Given this list of marker genes Cetn1, Tuba1a, Cetn4, Ccdc42, Cep131, Dctn1, C2cd3, Cdk5rap2 (NCBI Gene Id 72853), Haus8, Bnip2, Brca2, Brca1, Cntln, Ccdc15, Trim37, Ulk4, Nsfl1c, Chmp1b, Ubxn2b, Cep120, Pkhd1, Clasp1, 4933427D14Rik, Stil, Chmp2b, Pde4dip, Chmp2a, Pclaf, Cdc20b, Cep72, Chd3, Sgo1, Deup1, Kifc1, Ckap5, Haus7, Dzip1, Aurka, Xrcc3, Mcidas, Alms1, Pard6b, Fbxw5, Kat2a (NCBI Gene Id 76912), Ccdc57, Kif11, Arhgef10, Tmem67, Kif15, Bcl2l10, Ccnl1, Dnm2, Nde1, Xpo1, Ppp1r12a, Pard6g, Ccnf, BC034090, Atf5, Uxt, Cdk2 (cyclin dependent kinase 2), Clasp2, Xrcc2, Poc1a (POC1 centriolar protein A), Haus5, Azin1, Cep192, Rock2, Npm1, Haus4, Plk4, Cep76, Poc1b, Bbs4, Chordc1, Slc16a1, Sdccag8, Sass6, Chmp5, E2f4, Brsk1, Cep44, Wdr90, Nek2, Nin, Pcm1, Wdr62, Cep63 (centrosomal protein 63), Ctnnb1, Crocc, Cep135, Mapk8, Usp33, Ssx2ip, Pdcd6ip, Pafah1b1, Ccnl2, Ndel1, Plk1, Sac3d1, Itgb1bp2 (integrin beta 1 binding protein 2), Cep152, Gen1, Cep85, Cetn2, Chmp1a, Chmp4b, Poc5, Gcc2, Foxj1, Ccdc61, Uvrag, Nup62, Arl2, Ppp1r35, Cep250, Haus6, Cep68, Cep295nl, Mdm1, Ofd1, Map9, Fbxw11, Chmp4c, D7Ertd443e, Pard6a, Ranbp1, Plk2, Gadd45a, Kif3a, Fes, Rbm14, Cep295, Dync1li1, Rttn, Haus3, Nubp1 (nucleotide binding protein 1), Vps4b, Chmp3, Cenpj, Hepacam2, Haus1, Cntrob, Mark4, Cdk11b, Ndc80, Golga2, Nat10, Chek1, Mcph1, Spice1, Ccp110, Cenatac, Haus2, Cc2d1a, Kat2b, Sirt1, Ccdc78, here is a description of the gene set: A process that is carried out at the cellular level which results in the assembly, arrangement of constituent parts, or disassembly of a microtubule organizing center, a structure from which microtubules grow. species: Mus musculus Mouse Gene Set: GOBP_MICROTUBULE_ORGANIZING_CENTER_ORGANIZATION